Given this list of marker genes VTA1, CDK6, FASTKD5, GSPT1, CKS2, NR4A1, UBE2N, EVI2A, TRMT6, MRM3, IER3, MAPKAPK5, TTC27 (tetratricopeptide repeat domain 27), SLC7A1, TSPAN31, NECAP1, PEA15, ADCY3, DDX31, STK26, LMBR1, INTS12, ZEB1 (NCBI Gene Id 6935), CDK4, TIPIN, AP1S1, LRWD1, FAM241A, FEM1A, SLC27A2, ITK, PTPRE, ATP2A2, PSMB2, TRA2B, TRNT1 (tRNA nucleotidyl transferase 1), CAP1, UTP15, IL27RA, CHD4, PPP1R15B, BYSL, NSMF, ACTR3, NOLC1, COQ10B, SLCO4A1, TOP1, NOM1, NLE1, NUP188, PPP1R15A, INAFM1, GPR107, RUNX3, QTRT2, BUD31, PPAT, PRSS33, IER5, NUP58 (nucleoporin 58), NUP98, SLC25A32, NCBP1, UQCC4, EIF2S1, TXNRD1, CD83, TMX2, TFAM, ABCE1, ADAP1, SMIM15, SQSTM1, WDR33, RSL24D1, KBTBD8, UTP6 (UTP6 small subunit processome component), MOB1B, LTV1, BUD23, MAP3K14, PHF5A, NAB2, RRP7A, TIGAR, TAB2, BAIAP2 (NCBI Gene Id 10458), UBE2NL, PPRC1, PURB, METTL16, STRAP, NOP58, NPTN, CRLS1, USP12, RRP12, PITPNB (phosphatidylinositol transfer protein beta), HEATR1, LRRC8B, SPHK1, SUCLA2, ILF3, PSMB6, MIR155HG, EBNA1BP2, ILF2, RNF19A, BACH2, ESRRA, POLR2D, YTHDF3, ADSS2 (adenylosuccinate synthase 2), RCOR1, VDAC1, AGFG1, EGR3, MAK16, PDCD11, CSGALNACT2, PRMT1, SMURF1, CKLF, SLC35F2, PIGW, ZNHIT6, TNFRSF4, RAN, ZBTB43, CSRNP1, ZFP36, FAM3C, FTH1P5, FBXW7, MRTO4, EPOP, KIAA0753, RBM7 (RNA binding motif protein 7), NAT10, DRG1, USP4, TRAF1, TTC4, ARAP2, UBA2, ZNF473, C1orf216, CSNK1E, DESI1, KPNA1, MED21, SNORA28, TFB2M, GTF2B, BAZ1A, DERL1, USP14, ATP1A1, TNFRSF12A, PNO1, MIR17HG, NOC3L, POLR3D, FAM20B, EEF1E1, TNFSF14, CYSTM1, HSBP1, NDUFA6, KLC2, MAT2A, TCP1, TIMM8A, MRPL14, FUNDC2, TM9SF3, KMT5A, URB2, HUS1, HSP90AA1, NAA15, IARS1, MIDN, TET3, POLR3C, DMAC2L, GSR, KLF10, EIF5 (eukaryotic translation initiation factor 5), MED19, DNTTIP2, EXOSC9, PINX1, MED27, SNRPB2, SETMAR, HSPH1, EIF1B, here is a description of the gene set: Human Gene Set: GSE46468_LUNG_INNATE_LYMPHOID_CELL_VS_SPLEEN_CD4_TCELL_DN Innate lymphoid cells (ILCs) are a recently recognized heterogenous group of immune cells that are critical in orchestrating immunity and inflammation in the intestine, but whether ILCs influence immune responses or tissue homeostasis at other mucosal sites remains poorly characterized. Here we identify a population of lung-resident ILCs in mice and humans that expressed the alloantigen Thy-1 (CD90), interleukin 2 (IL-2) receptor a-chain (CD25), IL-7 receptor a-chain (CD127) and the IL-33 receptor subunit T1-ST2. Notably, mouse ILCs accumulated in the lung after infection with influenza virus, and depletion of ILCs resulted in loss of airway epithelial integrity, diminished lung function and impaired airway remodeling. These defects were restored by administration of the lung ILC product amphiregulin. Collectively, our results demonstrate a critical role for lung ILCs in restoring airway epithelial integrity and tissue homeostasis after infection with influenza virus. As part of this study, we performed gene expression profiling to examine how the transcriptional signatures compared between murine naïve group 2 lung ILC and group 3 splenic LTi cell populations. studied in species Homo sapiens from publication Monticelli LA, Sonnenberg GF, Abt MC, Alenghat T, Ziegler CG, Doering TA, Angelosanto JM, Laidlaw BJ, Yang CY, Sathaliyawala T, Kubota M, Turner D, Diamond JM, Goldrath AW, Farber DL, Collman RG, Wherry EJ, Artis D (PMID 21946417) Genes down-regulated in lung innate lymphoid cells versus spleen CD4 T cells.